The following is a description of a gene set: species: Homo sapiens Human Gene Set: GOBP_REGULATION_OF_TOLL_LIKE_RECEPTOR_7_SIGNALING_PATHWAY Any process that modulates the frequency, rate, or extent of toll-like receptor 7 signaling pathway., and this is the list of marker genes: RSAD2, DDX3X, TASL, SLC15A4, LILRA4, TREML4